The following is a description of a gene set: species: Mus musculus The acetylation of peptidyl-lysine. Mouse Gene Set: GOBP_PEPTIDYL_LYSINE_ACETYLATION, and this is the list of marker genes: Dip2a, Kat7, Prkaa2 (protein kinase, AMP-activated, alpha 2 catalytic subunit), Pml, Atat1, Esco1, Bag6, Hdac2, Bloc1s1, Kif3a, Kat5 (K(lysine) acetyltransferase 5), Kat2b (K(lysine) acetyltransferase 2B), Dip2b, Smo, Nat8f1, Prkaa1, Hint2, Nat8, Klf15, Ep300, Crebbp, Nat8f7, Sox4, Nat8b-ps, Sirt1, Smc5, Shh, Kat2a, Sirt3, Nfe2